Given this list of marker genes TRDV2, SIRPG, COL6A2, DBN1, IFNG-AS1, IGFBP2, CPNE2, CXCR3, PDCD1, ZNF683, TRG-AS1, IGFBP4, here is a description of the gene set: from publication He P, Lim K, Sun D, Pett JP, Jeng Q, Polanski K, Dong Z, Bolt L, Richardson L, Mamanova L, Dabrowska M, Wilbrey-Clark A, Madissoon E, Tuong ZK, Dann E, Suo C, Goh I, Yoshida M, Nikolić MZ, Janes SM, He X, Barker RA, Teichmann SA, Marioni JC, Meyer KB, Rawlins EL (PMID 36493756) Human Gene Set: HE_LIM_SUN_FETAL_LUNG_C4_NKT2_CELL species: Homo sapiens NKT2